The following is a description of a gene set: The directed movement of lactate into, out of or within a cell, or between cells, by means of some agent such as a transporter or pore. Lactate is 2-hydroxypropanoate, CH3-CHOH-COOH; L(+)-lactate is formed by anaerobic glycolysis in animal tissues, and DL-lactate is found in sour milk, molasses and certain fruit juices. species: Homo sapiens Human Gene Set: GOBP_LACTATE_TRANSPORT, and this is the list of marker genes: SLC16A8, SLC16A7, EMB (NCBI Gene Id 133418), ACACB, SLC16A1 (solute carrier family 16 member 1), SLC16A3, SLC5A8, SLC5A12